Given this list of marker genes CEP41, CPLANE1, ACADVL, NTNG1, TCTN2, CDKL5, RPGRIP1L, OFD1, CSPP1, TCTN3, MKS1, TMEM237, SMC1A, UQCRC2, TMEM231, PIBF1, MECP2, CEP104, CEP120 (NCBI Gene Id 153241), KIF7, TOPORS, TMEM218, CBY1, SUFU, TMEM67, KIAA0586, KATNIP, CEP290 (centrosomal protein 290), TMEM216, HYLS1, GABBR2, PDE6D, ARMC9, KIAA0753, INPP5E, FBP1, IFT74, B9D2 (NCBI Gene Id 80776), ARL13B, AHI1, FAM149B1, ARL3, TCTN1, B9D1, CC2D2A, TOGARAM1, here is a description of the gene set: Episodes of very rapid breathing. Human Gene Set: HP_EPISODIC_TACHYPNEA Episodic tachypnea species: Homo sapiens